The following is a description of a gene set: studied in species Homo sapiens Abnormal circulating atrial natriuretic peptide pro-hormone concentration The concentration in the blood circulation of atrial natriuretic peptide pro-hormone or one of its processed fragments is outside of the range of normal. Human Gene Set: HP_ABNORMAL_CIRCULATING_ATRIAL_NATRIURETIC_PEPTIDE_PRO_HORMONE_CONCENTRATION, and this is the list of marker genes: RASA1, MYZAP (myocardial zonula adherens protein), SDHD, LMNA (lamin A/C), HADHB, GAA, PSMB9, CAPNS1, TTR, BAG5, CORIN, TNNT2